Given this list of marker genes RAF1, IFNGR1, JAK1, MAPK1, JAK2, MAPK3, IFNG, IFNGR2, here is a description of the gene set: Interferon-gamma (IFNG) signaling results in transient activation of MAPK1 (ERK2) and MAPK3 (ERK1). IFNG-mediated MAPK (ERK) activation is JAK1-dependent and RAS-independent. It is thought to occur through JAK1-meidated phosphorylation of RAF1. Reactome Pathway: IFNG signaling activates MAPKs part of: Interferon gamma signaling studied in species Homo sapiens